Given this list of marker genes Gm40689, Gm29783, Gm24172, Gm32023, Gm32364, Gm24486, Zwint, Gm33979, Gm34609, Cabcoco1, Gm20108 (NCBI Gene Id 102636776), Gm30853, 4930543I11Rik, Gm32515, Mrln, Egr2, Gm33263, Gm7097, Gm19168, Cisd1, Gm19116, C730027H18Rik, Gm47903, Ank3, Gm18636, Bicc1, Gm31763, Gm18777, Gm46231, Gm5080, Gm46233, Gm22937, 4930545H06Rik, Pcdh15, Gm6331, Tfam, Tmem26, Gm34376, Gm4797, Arid5b, Gm7594, 1700030E10Rik, Slc16a9, Gm6419, Gm7034, Rhobtb1, Gm29774, A930033H14Rik, Gm10797, Gm5778, Gm34544, Zfp365, Gm31181, Nrbf2, Phyhipl, 1110002J07Rik, Fam13c, Gm28881, Gm26359, 4930407I19Rik, Gm22829, Gm24984, Gm19074, 4930551I15Rik, Gm9923, Ado, Gm7540, 1700049L16Rik, Gm6407, Gm4798, 4930521O17Rik, Ube2d1, Gm20609, Reep3, 1700023F02Rik, Gm47107, 1700048P04Rik, Gm4796, A330049N07Rik, Cdk1, Gm6362, Gm40685, Gm34776, Gm32025, Gm33035, 4930563J15Rik, Gm32255, Gm32872, 1700113B09Rik, Rpl19-ps2, Ccdc6, 4930533K18Rik, Ipmk, Rtkn2, Jmjd1c, Gm22594, here is a description of the gene set: Mouse Gene Set: chr10B5 studied in species Mus musculus